Given this list of marker genes APOC1, NF1, ESYT2, GPR119, CHMP3, PCYT1A, SCARB2, ABCA1, JCHAIN, ESYT1, VDAC2, PLTP, APOA5, IGHM, CHMP2A, SERPINA5, ESYT3, APOA4, PCYT1B, GPR12, RPE65, CETP, APOA2, PITPNB, ANXA13, PCTP, PITPNM2, PITPNM1, VDAC1, PITPNA, RASGRP1, SESTD1, here is a description of the gene set: Human Gene Set: GOMF_PHOSPHATIDYLCHOLINE_BINDING Binding to a phosphatidylcholine, a glycophospholipid in which a phosphatidyl group is esterified to the hydroxyl group of choline. studied in species Homo sapiens